The following is a description of a gene set: The process whose specific outcome is the progression of the pronephros over time, from its formation to the mature structure. In mammals, the pronephros is the first of the three embryonic kidneys to be established and exists only transiently. In lower vertebrates such as fish and amphibia, the pronephros is the fully functional embryonic kidney and is indispensable for larval life. Human Gene Set: GOBP_PRONEPHROS_DEVELOPMENT studied in species Homo sapiens, and this is the list of marker genes: LHX1, HNF1A, CEP290, AHI1, OSR2, OSR1, HNF1B, PAX8, PAX2, SEC61A1